The following is a description of a gene set: Whole blood genes. Human Gene Set: MODULE_45 studied in species Homo sapiens, and this is the list of marker genes: SLC19A1, KCNAB1, NR1D1, DOCK2, DVL1, BTN3A2, LSP1, EMP3, TNFRSF10C, RNASE6, ORM2, ARHGAP4, TNFAIP3, CCHCR1, GYPB, TBC1D2B, ACKR2, EDC4, SLPI, JUNB, PTPRC, C2, CD6, RAC2, ASGR1, NHERF1, QPCT, IGSF6, TNFAIP8, PTPN7, PTK2B, CCR1, GMFG, OLFML2B, SLC18A3, SPI1, PRELID3A, RGS2, S100A8, ARID3A, IQGAP2, SERPINE1, CRIP1, FCGRT, RCBTB2, PTPN6, INPP5D, SRCAP, DOK2, TTLL12, DGKA, MAGI1, SDC1, TBC1D9, PTPN9, TNFRSF10D, ALOX5, SULT4A1, ENTPD2, SLC6A7 (NCBI Gene Id 6534), KCNA5, KCNJ4, COMP, MKNK1, ITGA2B, LY6G6C, MPP1, FST, LCE2B, H2AC6, PIM2, PLSCR1, DOK1, IL1RN (NCBI Gene Id 3557), GCH1 (GTP cyclohydrolase 1), AGER, DPYSL4, SLC16A6, KDM5C, COL2A1 (NCBI Gene Id 444981), KCND3, ARL6IP5, TNFAIP6, HAP1, FGL2, ARHGAP25, STAT5A, STAT6, TYMP, GPSM3, CAPG, SFTPC, LRIT1 (leucine rich repeat, Ig-like and transmembrane domains 1), ARAP1, CRHR2, LGALS9, EVI2B, CD86, HTR4, STAB1, CHST15, LPAR2, TNFRSF10B, ABCA1, ELN, N4BP2L1, PRRC1, CD58, KRT4, RASGRP1, RHOG, SLC11A1, SEMA4D, SLC2A3, S100P, CSTA, S1PR4, ATP2A3, IGHG3, MMP9, CD22, REL, PI3, AQP3, ATM, ARL4C (ADP ribosylation factor like GTPase 4C), SLC2A1, SPN, SLC6A6, MNDA, APOM, OASL, FCER1G, SRGN, IL27RA, IFIT1, CARD10 (NCBI Gene Id 29775), POU4F1, GMPR, NAMPT, GRN, LY86, FPR2, PTP4A3, GLIPR1 (NCBI Gene Id 11010), ARHGDIG, NMI, ADM, SASH3, MAT1A, CASP1, CD55, FLT3, ITGA5, FCGR3B, IRF1, CD53, TULP1 (TUB like protein 1), TACC2, IGF1, VCAN, ASAH1, CORO1A, IFI35, PSMB8, DPYD, VPS11, NFKB2, MEGF9, GLRX, CTSC (NCBI Gene Id 50958), SLC5A2, STAT4, HCAR3, TRIM22, RASSF2, SLC7A11, PFKFB4, STAT1, GPA33, SLA (Src like adaptor), AANAT, TBX1, PPP3CC, TNXB, PTPN12, HEG1, RAB4B, CD300A, DOLK (NCBI Gene Id 22845), CPVL, LAIR1, PNRC1, CSF3R, GATA1, PF4, CRABP1, SYK, CD247, FBN2, SIX6, WAS, IVD (NCBI Gene Id 3712), ARHGEF6, TLR2, FCMR, AQP9, CCR3, GJB1, IRAG2, BCL2A1, LYN, FOSL2, IL13RA1, ACAP1, TNF, IKBKG, SECTM1, CX3CR1, CDA, SP110, LAPTM5, KLRC3, IMPA2, CASP4, CCL15, NFKBIB, ST6GAL1, CCDC9, VAV1, PCOLCE, SCAMP5, SLC7A7, CCND2, CCNF, IL1B (NCBI Gene Id 3553), SLC43A1, KRT31, H2BC12, PFKFB2, GJB5 (gap junction protein beta 5), IFI16, PLAAT4, SELPLG, HTR7, IFNGR1, PLEKHO2, S100A9, ADGRE5, SH3BP1, TSC22D3, TARBP2, IL1RAP, RAB8A, SLC22A18AS, PTPRE, TGFB1, SOD2, NEURL1 (NCBI Gene Id 9148), LPCAT1 (lysophosphatidylcholine acyltransferase 1), F13A1, ADCY7, RGS10, CTSS, INHBC, IL2RB, SLC31A2, CYP1B1, ICAM3, CHST1, WNT10B, GBP1 (NCBI Gene Id 2633), KCNQ1, SYNE1, CSPG4, STX11, LILRB3, TFF2, AHSG, ATP4A, PDE4B, PTGS1, CRYBA4, TCIRG1, KCNK3, VSIG4, FMNL1, LCP2, MMD, PHKG1, IL10RA, CD2, TRDD3, IDS, BIRC3 (NCBI Gene Id 330), ALOX5AP, FCGR3A, CEACAM4, HLA-DQB1, MAPKAPK3, IL4R, JAK3, HLA-DMA, SLC6A2, HTR3A, IER3, TBX19, CA4 (NCBI Gene Id 762), BCKDHA, ISG20, DLX4, PRKCD, CD14, CDK5R1, SATB1, APOC4, PSD4, CEACAM3, PLCB2, RAD51D, PSG7 (pregnancy specific beta-1-glycoprotein 7), ECE2, NRGN, UBN1, MAN2B1, EXOSC2, AIF1, NINJ1 (NCBI Gene Id 4814), RPS6KA1, MVP, LTB, HTRA2, BMP1, S100A11, HSPA6 (heat shock protein family A (Hsp70) member 6), ITGAM, ANPEP, SLC16A3, FHIT, SNX1, IFFO1, IQSEC1, ASIC2, DAPK2, TNFRSF13B, PRF1, GZMA, CFD, PIGR, TCL1A, TCF7, PDGFRA, ACTN1, LST1, SLC13A2, PRKCB, NKG7, PAX9, ARHGDIB, IL3RA, ATP11A, TRIB2, ELF4, SFTPD, KRT86 (keratin 86), MAP4K1, TNFAIP2, PYGL, HCLS1, GFPT2 (NCBI Gene Id 9945), ATP1B2, CD8A, TP53I11, FDXR, IL7R, MAST3, ST3GAL5, PLCG2, DNM2 (NCBI Gene Id 338330), LIF, ANXA1, UBE2D1, M6PR, PFKFB3, IGHM, UBXN1 (NCBI Gene Id 92151), TRANK1, SCN2B (sodium voltage-gated channel beta subunit 2), KIAA0513, HMOX2, TBXAS1, MUC1, LLGL2, SNRK, CD48, IFI44, LIPA, ARC, PTPRCAP (protein tyrosine phosphatase receptor type C associated protein), CLCNKA, SP100, CYP11A1, SEMA6C, VAV2, ZKSCAN7, DENND3, PIM1, AOAH, XDH, ALAS2, FCN1, NCF4, TNFRSF25, PKN1, RAC3, ALPL, CD44, FCGR2A, CD34, CELF2, DDX3Y, TLR1 (toll like receptor 1), CD79A, IL3, ADAM19, TAF1, RNASE2, MARF1 (meiosis regulator and mRNA stability factor 1), UBE2L6, CNTN6, TAP1, CD3E, KCNAB2, EVI2A, CD8B, IL32, GBP2, NCF1C, PLK3, DENND4B, CFP, LAMP2 (NCBI Gene Id 3920), S100A4, ARHGEF1, NFYC, CYBB, ITGB2, LMO2, PECAM1, KYNU (NCBI Gene Id 8942), HLA-DRB4, LILRB5, ZYX, PLCL2, PIGA, THRA, CADPS2, HPS1 (HPS1 biogenesis of lysosomal organelles complex 3 subunit 1), FADS1, EFNA2 (ephrin A2), BCL6 (NCBI Gene Id 604), AMELX, HTR6, CD52, GZMK, LMO4, LPXN, ZIC2, JCHAIN (joining chain of multimeric IgA and IgM), LCK, GIT2, ITGB7, SERPINA1, STMN1, ATOSB, LRCH4, CYP4B1, IKZF1, NRG2, IFIT3, P2RY10, CXCL8, CCL5, DEFA3, CD302, PIK3CD, CLEC2B, ARPC4, ACSL1, MYEF2, EDA, FLNA, CD300C, ADAM8, NTSR2, PSMB9, KCNQ3, TNFRSF1B, ID2B, PPBP, HTR2A, KIF21B, SKAP2, CYP26A1, KLRK1, RAB31, LILRA2, CEP135, NFIL3, GZMB, H2BC21, SIPA1 (signal-induced proliferation-associated 1), STAT2, MME, FAM53B, PLEK (pleckstrin), LY96 (lymphocyte antigen 96), CNTN2, ITGA6, SBNO2, HCK, DPH2, CXCR4, MAP2K3 (mitogen-activated protein kinase kinase 3), SCO2, DUSP6, SNCG, SKAP1, TNFSF10, ACR, ANKRD12, ZBED4, GNG11, MPPED1, P2RX1, HK3, PPP5C, ST6GALNAC4, CLDN9, FYB1, KDM5D, IL2RG, DLEC1, CORT, UGT2B15, PPP4R2, PSMB10, SERPINB1, ZMIZ1, DPT (dermatopontin), EFS (embryonal Fyn-associated substrate), CPD, FCGR2B, ITGAL, CD37, FGR, LCP1, MAL, NCF2, FUT7, TGFBR2, ITGA10, GNLY, PRKACB, CD3D, DKK4, MFAP2, MCRS1, RAB5C, CSF2RB, ODF1 (outer dense fiber of sperm tails 1), PTAFR, MX2, LILRB2, SELL, AP1M1, LIMK2, METAP1, NNAT, CST7, TGFBI